The following is a description of a gene set: Mouse Gene Set: GOCC_TROPONIN_COMPLEX species: Mus musculus A complex of accessory proteins (typically troponin T, troponin I and troponin C) found associated with actin in muscle thin filaments; involved in calcium regulation of muscle contraction., and this is the list of marker genes: Tnnt2, Tnnt3, Tnni3, Tnnc1, Tnnc2, Tnni1, Tnnt1, Tnni2